Given this list of marker genes TMEM86A, GAS1, LRRN3, ZFP28, RAB30, CDC42EP2, EVI2A, ZNF521, SVIL, NUF2, PCDH9, USP18, ZIC1, TK1, VWA5A, IFIT3, STAT1, PWWP3B (PWWP domain containing 3B), EYA1, DTL, MPPED2, PLPP3 (NCBI Gene Id 8613), RCBTB2, DIXDC1, SYT11, IGF1, ACSS2, LRRCC1, SORBS2 (NCBI Gene Id 8470), ARRDC3, FAT4, MEF2C, PDLIM2, CCL15, CYP1B1, RFC3, CENPJ, MALAT1, NFIB, MRGPRF, PTPRD, FOXC1, TCF7L2, GAMT, G6PD, TSHZ1, LMO7, IDH1 (NCBI Gene Id 3417), CBX6 (NCBI Gene Id 23466), ARHGAP18, EPHA7, MAP2, IFIT2, MEST, GSTM1, KCND2, ADGRG2, RTP4, MARCKS, NFIA, IL18, ARNT2, PRICKLE2, TMEM53, PRSS35, ARID5B, CAVIN2, SERHL2, IRGM, DDIT4L, MAN1A1, TRIM21, LDB2, EPHX1, GBP2 (NCBI Gene Id 2634), CD36, GULP1, RASGRP3, LAMA4, PHIP, SH3BP5, MGST1, IFIT1B, PIK3R1, LIFR, SLC14A1, MT1F, ADHFE1, GAS2, CTNNAL1, PLSCR1, TRPS1, SESN3, SERPINB1, SBK1, THSD7A, KITLG, NR1D2, ZFHX4, CDH2, ZFAND1, BUB1, RSPO3, MEIS2, CD24, KLHL24, SERPINB6, WDR19, GLRX, SCARA5, SORD, CALHM5, RARB, EBF3, ITGB3BP, TCEAL1, LPL, FIGNL1, CENPK, MKI67, ADAMTS5, ELOVL6, PLCB1, ANGPT2, THBD, CNKSR3, SHOX2, TCEA3, FOXP2, OASL2P, MRC1, DDC, LILRB1, ABLIM1, SLC16A4, IGFBP5, VCAM1, FMNL2, IL6ST, SLC12A2, LGR4, SESN1, FGFR2, SERPINB9, SCARA3 (scavenger receptor class A member 3), SH3BGRL, ARL6IP1, OGN, PARP9, PDK4, MSH6, MMP11, ZNF467, STMN2 (stathmin 2), CD93, KNSTRN, EIF2AK2, MBNL3, PLEK (NCBI Gene Id 5341), C3AR1, STMN1, RNASEL, MLLT3, SLC24A3, BNIP3L, UNC5C, ARHGAP20 (NCBI Gene Id 57569), NQO1, AUTS2 (NCBI Gene Id 26053), EDNRB, TMT1A, DBP, PDE1A (NCBI Gene Id 5136), PMP22, CDKN3, MMP16, SIM2, PCDH7, MASTL, NMI, SEMA3A, PALMD, SMARCA2, RUNX1T1 (RUNX1 partner transcriptional co-repressor 1), AGTR2, SLC40A1, RSPO2 (NCBI Gene Id 340419), PBX1, RND3, DZIP1, CCL2, PRIM1, ACADM, TLE6 (NCBI Gene Id 84846), ADM (NCBI Gene Id 133), PER3, NPR3, CASP12, FGF7, HMMR (hyaluronan mediated motility receptor), AQP1, PLEKHH2, HACD4, ADGRG6, NUSAP1, S1PR3, NFIX, TRIM2, ZNF608, ADAMTS1, MED12L, RFC4, HERC6, CPA6, LUM, PDE5A, DHRS3, SIX1, OSR1, DCLK1, PTEN, ARHGAP28, DAB2, PDGFRA, REPS2, MTERF2, ZWILCH, LPAR4, PLEKHG1, PRKAR2B, IL1RN (interleukin 1 receptor antagonist), EYA4, AMPD3, HOXC10, TGFBR3, CCNB1, RTL3, PIK3R3, PDP1, PPP1R3C, TOX (NCBI Gene Id 9760), VEGFD, DIRAS2, PTX3 (pentraxin 3), PRRX1, CAND2, IRS1, FBXL7, CELF2, CLIP4, PEG3, CYP7B1, TRIM37, here is a description of the gene set: species: Mus musculus Human Gene Set: PLASARI_TGFB1_TARGETS_10HR_DN from publication Plasari G, Calabrese A, Dusserre Y, Gronostajski RM, McNair A, Michalik L, Mermod N (PMID 19752192) Genes down-regulated in MEF cells (embryonic fibroblast) upon stimulation with TGFB1 for 10 h. Transforming growth factor beta (TGF-beta) and platelet-derived growth factor A (PDGFAlpha) play a central role in tissue morphogenesis and repair, but their interplay remain poorly understood. The nuclear factor I C (NFI-C) transcription factor has been implicated in TGF-beta signaling, extracellular matrix deposition, and skin appendage pathologies, but a potential role in skin morphogenesis or healing had not been assessed. To evaluate this possibility, we performed a global gene expression analysis in NFI-C(-/-) and wild-type embryonic primary murine fibroblasts. This indicated that NFI-C acts mostly to repress gene expression in response to TGF-beta1. Misregulated genes were prominently overrepresented by regulators of connective tissue inflammation and repair. In vivo skin healing revealed a faster inflammatory stage and wound closure in NFI-C(-/-) mice. Expression of PDGFA and PDGF-receptor alpha were increased in wounds of NFI-C(-/-) mice, explaining the early recruitment of macrophages and fibroblasts. Differentiation of fibroblasts to contractile myofibroblasts was also elevated, providing a rationale for faster wound closure. Taken together with the role of TGF-beta in myofibroblast differentiation, our results imply a central role of NFI-C in the interplay of the two signaling pathways and in regulation of the progression of tissue regeneration.